Given this list of marker genes INO80, DHX35, CDC42EP4, ZNF189, PIK3CA, PLEKHG4B, OR12D3, DBX2, VDAC2, VPS26A, TMEM117, SMURF1, DOCK4 (NCBI Gene Id 9732), ZCCHC17 (zinc finger CCHC-type containing 17), CD84, FAM193A, AP3M1, GSS, SLC4A4, WNT10B, SPTSSB, TPO, MLEC, ADCY1, HNRNPL, SRSF6, SMAD1, SEZ6, GRIP1 (NCBI Gene Id 23426), ZDHHC5, SMAP1, HMGA2, DCBLD1, RAP1GDS1, SCG3, NR4A3, SH3PXD2A, GPD1, SYNJ2BP-COX16, SEC22C, UPF1, PMAIP1, MAU2, PEAK1, CES3, ADGRA2 (adhesion G protein-coupled receptor A2), MTMR1, CNTNAP1, MGMT, TMEM161B, ING3, DSTYK, TPM4 (tropomyosin 4), ERVV-2, PRTFDC1, CCDC198, CEP112, AR, TADA1, BACH2, MTCL2, ZNF827, ATXN7L3, APOBEC3F, TRIM33, ZDHHC15, CHST11, CHST15, BAZ2A, ATP11A, PAG1, MBNL1, ATXN1, KLF12, USP37, IFIT1, FLT1, PSD3, RAPGEF1, SLAMF6, FOXO1, CASKIN1, LRRK1, RNF20, RFX7, OSCAR, BICD2, COX16, MAP4K4, HSPA12A, CHD2, here is a description of the gene set: studied in species Homo sapiens Genes predicted to be targets of miRBase v22 microRNA hsa-miR-6893-3p in miRDB v6.0 with MirTarget v4 prediction scores > 80 (high confidence targets). Human Gene Set: MIR6893_3P from publication Chen Y, Wang X (PMID 31504780)